Given this list of marker genes Notch2 (notch 2), Pkd1, Slc22a1, Abcc2, Slc22a6, Aqp1, Aqp11, Acat1, Commd5, Dll1, Ctns, Heyl, here is a description of the gene set: Mouse Gene Set: GOBP_PROXIMAL_TUBULE_DEVELOPMENT The process whose specific outcome is the progression of the proximal tubule over time, from its formation to the mature structure. In mammals, the proximal tubule is a nephron tubule that connects Bowman's capsule to the descending thin limb of the loop of Henle. It has a brush border epithelial morphology. studied in species Mus musculus